Given this list of marker genes Penk, Cckbr, Ephb2, Shank3, Grpr, Npas2, Rag1, Apoe, Grp, Gja1, Mef2c, Cck, Crh, Ucn, Prkar1b, here is a description of the gene set: Any process that modulates the frequency, rate or extent of fear response. species: Mus musculus Mouse Gene Set: GOBP_REGULATION_OF_FEAR_RESPONSE